The following is a description of a gene set: species: Homo sapiens Human Gene Set: GSE29949_DC_BRAIN_VS_MONOCYTE_BONE_MARROW_DN To understand the functional relationship between brain dendritic cells (brain DCs) and other myeloid cells, we compared the gene expression profile of m/chDCs to that of bone marrow monocytes, brain microglia and classical spleen CD8+ and CD8- DCs. In order to obtain enough brain DCs for mRNA extraction, we expanded brain DCs with in vivo Flt3L treatment before purification. from publication Anandasabapathy N, Victora GD, Meredith M, Feder R, Dong B, Kluger C, Yao K, Dustin ML, Nussenzweig MC, Steinman RM, Liu K (PMID 21788405) Genes down-regulated in brain dendritic cells versus bone marrow monocytes., and this is the list of marker genes: UGCG, SPRR1A, IMPA2, IFT27, PLA2G7, BAK1, RNF113A, JAG1, MSMB (microseminoprotein beta), P2RY2, NKX2-2, ARL1, HSPH1, AFP, EPHB3, CD38, PLCB4, FTL, KDM7A, CD27, S1PR4, PTPRJ (NCBI Gene Id 5795), SLC27A2, DTX4, DUSP8, PLCD1, ARHGAP45, FABP2, HDAC4, TRAP1, MOK, SAMD14, ATP10D, AGTR2, PRODH2, RPS6KA1, GIP, GRM7, CACNA1B, DHH, BBIP1, HCG9 (NCBI Gene Id 10255), CCS, PNPLA2, SLCO1B1, KRT75, HBP1, RFNG, PSMF1, GPR6, FOXN2 (forkhead box N2), GAMT, MBD1, LRIG2, CASQ2, DNAJB12, LMO4, ISG15, MAPKBP1, LYST, LORICRIN, DEPP1, FGL1, HIPK2, CD48, SCGB1D2, SMPDL3A, PPP2R3A, TNFSF10, EPHB1, CST7 (cystatin F), PAX3, MEIS3P1, CACNB2, KCNJ13, PTGER2, TEK, COLGALT2 (collagen beta(1-O)galactosyltransferase 2), RBM15B, FST, RUNDC3A, ELAVL4, KLF4, MAGEA4, ABCB11, IFI6, BCL3, GMFG, FDX1, PROM1, BCAT1, TNFSF8, KHDRBS2, KITLG, IFITM3, TRAF4, TRH, PBXIP1, SHB, CLCA1, H2AC17, WIPI1, PPARA, LYPD1, SERPINE1, ALDH1L1, GRB14, SPINT3, SLC15A2, HNF1A, PPP3CA, IRF8, CST6, MUC1, STX11, NGFR, CD36, MOXD1, CLCN2, KNOP1, PARP4, MX2, RPUSD2, SRD5A2, USP13, DNASE1L3, LEFTY2, PCDHA13, GRK3, PTCH1, IGLV3-25, MC1R, IL13RA1, PLLP, ADAM21, HEXIM1, DTNB, CPNE1, SNCA, KDM5C, FAM161A, SENP6, ZKSCAN4, NFKBIL1, LTB, LRRC14, NEBL, ACR, NOL3, NAT9, POFUT2, CYP2C18, PFKFB1, PGM3, OTC, RMND5A, CBARP, MYT1L, RHBDD3, TRPC2, CNTFR, PLCH2, GPR12, CITED2, ADCY9, ANGEL1, SWAP70, MAML3, CD59, KLF12, CEACAM1, ZBTB7B, RCN1, CAPN7, APOA4, MGST2, COL9A1, TMEM123, BTBD3, IGHM, ABTB2, CEBPE, RAMP1, LRRN3, ASS1, RSC1A1, H1-4, PNLIPRP1, PPM1F, PDLIM7, ATM, CASP4, MMP10, PLA2G15, ADCY2, ZNF101, NMI, UHRF2